The following is a description of a gene set: Any process that activates or increases the frequency, rate or extent of T cell death by apoptotic process. studied in species Homo sapiens Human Gene Set: GOBP_POSITIVE_REGULATION_OF_T_CELL_APOPTOTIC_PROCESS, and this is the list of marker genes: TP53, PDCD1, TGFB2, WNT5A (NCBI Gene Id 7474), BCL2L11, P2RX7, PRELID1, ZC3H8, LGALS9, CD274, IDO1 (NCBI Gene Id 3620), ADAM8, CCL5, BBC3, LGALS16, PERP (NCBI Gene Id 64065)